The following is a description of a gene set: species: Mus musculus Genes positively differentially expressed in cell type: MigDC (migratory dendritic cell) upon treatment with cytokine: Leptin in mouse lymph nodes in vivo. Mouse Gene Set: CUI_MIGDC_LEPTIN_RESPONSE_UP from publication Cui A, Huang T, Li S, Ma A, Pérez JL, Sander C, Keskin DB, Wu CJ, Fraenkel E, Hacohen N (PMID 38057668) Cytokines mediate cell-cell communication in the immune system and represent important therapeutic targets. A myriad of studies have highlighted their central role in immune function, yet we lack a global view of the cellular responses of each immune cell type to each cytokine. To address this gap, the authors created the Immune Dictionary, a compendium of single-cell transcriptomic profiles of more than 17 immune cell types in response to each of 86 cytokines (>1,400 cytokine-cell type combinations) in mouse lymph nodes in vivo. A cytokine-centric view of the dictionary revealed that most cytokines induce highly cell-type-specific responses. For example, the inflammatory cytokine interleukin-1β induces distinct gene programmes in almost every cell type. A cell-type-centric view of the dictionary identified more than 66 cytokine-driven cellular polarization states across immune cell types, including previously uncharacterized states such as an interleukin-18-induced polyfunctional natural killer cell state., and this is the list of marker genes: Nsmce1, H2-T23, Tmbim6, Ccng2, Mreg, Tap2